Given this list of marker genes Tnf, Zfp36, Ifitm7, Ifi213, Trim8, Ptx3, Hexim1, Larp7, Hmga2, Rsad2, Ifi208, Mndal, Tasor (NCBI Gene Id 74444), Oas1d, Ifi203-ps, Bst2, Inpp5k, Mid2, Trim6, Oas2, Trim14, Ch25h, Ifitm1, Oasl2, Oas1a, Shfl, Ifnb1, Apobec3, Trim13, Ifi207, Rnasel, Trim11, Trim31, Trim21, Banf1, Ifih1, Ilf3, Zc3hav1, Ccl5, Crebbp, Ltf, Ifi203, Srpk1, Ubp1, N4bp1, Trim28, Mbl2, Fam111a, Larp7-ps, Mavs, Apcs (amyloid P component, serum), Isg20, Ifitm3, Oas1h, Aicda, Trim27, Ifitm2, Ifitm6, Prox1, Oas1f, Csnk2b, Oas3, Sp100, Oas1e, Mx2, Plscr1, Trim62, Vapb, Oas1c, Mphosph8, Slpi, Znfx1, Zfp809, Ppia, Ifi209, Ifnl3 (interferon lambda 3), Isg15, Ark2n, Ifi206, Setdb1, Eif2ak2 (NCBI Gene Id 76759), Oasl1, Stat1, Trim15, Morc2b, Ifi214, Oas1g, Morc2a, Trim32, Srpk2, Oas1b, here is a description of the gene set: species: Mus musculus Mouse Gene Set: GOBP_NEGATIVE_REGULATION_OF_VIRAL_PROCESS Any process that stops, prevents, or reduces the frequency, rate or extent of a multi-organism process in which a virus is a participant.